The following is a description of a gene set: studied in species Mus musculus Phosphorylation of Emi1 Mouse Gene Set: REACTOME_PHOSPHORYLATION_OF_EMI1, and this is the list of marker genes: Cdk1, Ccnb1, Fbxo5, Cdc20, Fzr1, Plk1